The following is a description of a gene set: Human Gene Set: MIR4531 from publication Chen Y, Wang X (PMID 31504780) Genes predicted to be targets of miRBase v22 microRNA hsa-miR-4531 in miRDB v6.0 with MirTarget v4 prediction scores > 80 (high confidence targets). species: Homo sapiens, and this is the list of marker genes: MINDY2, ATF7IP, ADAMTS9, CNTN3, GPR26, COLEC11, SYNJ1, TTN, SDC1, VEZF1, ZDHHC15, HP1BP3, SH3GL2, SYT17, SAR1A, FBXW7, UBE2QL1, SGMS1, ESF1, PITPNB, PAPOLB, PSD2, PAFAH1B2, THSD7A, APELA, GJA1, PIK3CB, TRAF3, SLC29A1, HNRNPU, ANKRD34B, SERF2, COL4A5, AUTS2, C15orf40, ASPH, ARRB1, KIAA1549, PPP3CC, DIPK2A, FNBP4, EMC4, SLC35A1, TNFRSF21, CEACAM1, TMEM135, CLN5, PDE4A, ZBTB20, CDYL (NCBI Gene Id 9425), SUMO2, ZNF24, WDR26, ARHGEF4, ZCCHC14, ZEB2, TUB, LRCH1, CRYBG3, SCAMP1, LONRF2, SLC35B4, HMGN4, SLCO6A1, FOXO3, BMP2, SF3A3, TRIP6, ARPP19, THRB, PSD3, TXNRD1, SNIP1, CX3CL1, RNF217, CCDC120, STAT2, DOK6, EPC1, BACE1 (NCBI Gene Id 23621, beta-secretase 1), ZFP82, EIF4E3, QSER1, TAOK1, NEDD4L, MMD, CELF2, ZNF106, EDA2R (NCBI Gene Id 60401), TCF12, ZC4H2, SCAF8, SLC16A7, EIF4E, WASF3, KSR2, TFPI, SLC4A5, ORMDL2, TRMT9B, FBXO21, AKTIP, TPGS2, HSF2, REST, SP7, PRKAB1, SUZ12, MYO1D, F9, ST3GAL3, SYPL2, HAL, RBM23, SPATA6L, CUX1, LRATD1, OLFM3, CDK6, SCN3B, PALM2AKAP2, CSRNP3, GPC6, CCDC40, CADPS2, ATPAF2, NDUFB5, SEPTIN9, ADARB2, CREB5, MSI2 (NCBI Gene Id 124540), PAX5 (paired box 5), SLC24A2 (solute carrier family 24 member 2), SASH1, ING4, SVIP, CHEK1, PDE3B, FBXL20, DPYSL3 (dihydropyrimidinase like 3), ZNF587, SLC15A2, HOXA9, WIPF2, ENTREP2, CLVS2, GNB4, CD28, ALKBH1, PLAGL2, MAN1A2, GFPT2, COL25A1, SESN1, DDC, ABLIM1, LSAMP, BPGM, KLF12, XRN1, DCX, DOK3, DDX6, PPAT, TTC21B, MS4A1, CAMK4, ZNF385D, SLC1A2, DDX3X, PNRC2, TBL1X, APOC4, GTDC1, VSIG10, PTPRC, MS4A2, CD209, PRR23D1, TSPAN12, ELL, CALN1, PDE1C, BAAT, THOC5, PDE12, ZBTB2, HEATR5A, SERPINB13, METTL8, WDHD1, DDAH1, FSTL4, METTL4, CD53, SCAI, ABHD2, GSPT1, IKZF1, GOLGA7B, DCAF12L1, KLF7, KDM7A, CD276 (CD276 molecule), RPRD1A, AMD1, ELMOD2, DEPTOR, SLC35F2, TFRC, PPP1R12B, PHC1, ANTXR2, KCTD12, CADM4 (NCBI Gene Id 199731), TAF7, RTL4, SLC35A3, AMER1, AAK1, PIWIL2, RBPMS2, GOT2, DAZL, GATAD1, USP27X, HPS1, FEM1C, USP33, HTR2A, CALCOCO2, FAM210B, CPEB2, NFATC2, CUL4B, CREBRF, XYLB, MCPH1, AK6, WNT9B, PPP2R1B, SMARCAD1, APH1A, RABGAP1L, CER1, ZNF148, ADI1, ZNF780B, USP6NL, KCNN3, LYSMD1, SLC11A2, PLAGL1 (PLAG1 like zinc finger 1), PATE4, AMER2, PDLIM5, TMPO, ZFAND5, MED17, PHF8, DBT, TWF1, FBN1, SET, ZPLD1, RECQL5, LRRC1, EYA2, SMIM8, SLC12A8, CAMK2N1, CLEC12B, FAM120C, ST18, MED14OS, SEMA3C, EGLN3, PAPOLA, GNG12, HECTD2, ADAM28, OPRM1, KIAA0040, MCM8, MSANTD3, TBC1D7, GPR78, SPANXN1, ISG20, LIN7C, SENP5, TBC1D8B (TBC1 domain family member 8B), NRSN1 (neurensin 1), ACTN1, SLIT1, MAPDA, IKZF2, PTCH1, DHRS2, EPHA6, CCNT1, FN1, AHCYL2, PUM2, DENND6A, SNX20, LYST, PLEKHS1, SP100, PNOC, OPCML, PLCL2, ARHGAP12, SH3RF1, MASP1 (NCBI Gene Id 5648), JMJD6, TBC1D4, TESC, TOX3, EIF4B, ZKSCAN8, FKBP14, SLC23A2, CDH7, MLX, CYSLTR2, CIMIP6 (ciliary microtubule inner protein 6), SPATA33, PGD (phosphogluconate dehydrogenase), INTS6, FRAS1, CCDC186 (NCBI Gene Id 55088), DAZ3